Given this list of marker genes CDS1, COL11A1, AP1M2, EPN3, GPRC5A, KRT18, here is a description of the gene set: species: Homo sapiens Genes down-regulated in the normal-like subtype of breast cancer. Human Gene Set: SMID_BREAST_CANCER_NORMAL_LIKE_DN from publication Smid M, Wang Y, Zhang Y, Sieuwerts AM, Yu J, Klijn JG, Foekens JA, Martens JW (PMID 18451135) We explored whether the five previously reported molecular subtypes in breast cancer show a preference for organ-specific relapse and searched for molecular pathways involved. The intrinsic gene list describing the subtypes was used to classify 344 primary breast tumors of lymph node-negative patients. Fisher exact tests were used to determine the association between a tumor subtype and a particular site of distant relapse in these patients who only received local treatment. Modulated genes and pathways were identified in the various groups using Significance Analysis of Microarrays and Global Testing. Bone relapse patients were most abundant in the luminal subtypes but were found less than expected in the basal subtype. The reverse was true for lung and brain relapse patients with the remark that absence of lung relapse was luminal A specific. Finally, a pleura relapse, although rare, was found almost exclusively in both luminal subtypes. Many differentially expressed genes were identified, of which several were in common in a subtype and the site to which the subtype preferentially relapsed. WNT signaling was up-regulated in the basal subtype and in brain-specific relapse, and down-modulated in the luminal B subtype and in bone-specific relapse. Focal adhesion was found up-regulated in the luminal A subtype but down-regulated in lung relapse. The five major molecular subtypes in breast cancer are evidently different with regard to their ability to metastasize to distant organ(s), and share biological features and pathways with their preferred distant metastatic site.